The following is a description of a gene set: The regionalization process that creates areas within the forebrain that will direct the behavior of cell migration in differentiation as the telencephalon develops. Mouse Gene Set: GOBP_TELENCEPHALON_REGIONALIZATION studied in species Mus musculus, and this is the list of marker genes: Nr2f1, Bhlhe22, Bmp4, Emx1, Eomes, Six3, Tra2b, Dmrta2, Otx2, Gsx2, Emx2, Shh, Bmp2, Adgrg1, Lhx2, Pax6